The following is a description of a gene set: studied in species Homo sapiens Human Gene Set: GOMF_LONG_CHAIN_FATTY_ACID_TRANSMEMBRANE_TRANSPORTER_ACTIVITY Enables the transfer of a long-chain fatty acid from one side of a membrane to the other. A long-chain fatty acid has an aliphatic tail containing 13 to 22 carbons., and this is the list of marker genes: FABP2, ABCD3, MFSD2A, SLC27A1, SLC27A5, FABP3, SLC2A1, ABCD2, SLC27A4, CD36, SLC27A6, ABCD4, ABCD1, SLC27A2, FABP5, FABP4